The following is a description of a gene set: Catalysis of the reaction: inositol phosphate + ATP = inositol phosphate + ADP. studied in species Mus musculus Mouse Gene Set: GOMF_INOSITOL_PHOSPHATE_KINASE_ACTIVITY, and this is the list of marker genes: Ip6k3, Ippk, Ppip5k2, Itpk1, Ip6k2, Ppip5k1, Itpka, Itpkc, Ip6k1, Itpkb, Ipmk (inositol polyphosphate multikinase)